The following is a description of a gene set: Human Gene Set: GSE3039_CD4_TCELL_VS_NKT_CELL_DN studied in species Homo sapiens Three innate (B1-B, NKT, CD8aaT cells) and adaptive (B2-B, CD4T, CD8abT cells) cell-types were sorted by FACS. Three biological replicates for NKT, CD4T, CD8aaT, CD8abT cells and two biological replicates for B1 and B2 cells were generated and the expression profiles were determined using Affymetrix Mu74Av2 chip. Comparisons between the sample groups allow the identification of genes differentially expressed between the innate and adaptive cell-types. Genes down-regulated in CD4 T cells versus NKT cells. from publication Yamagata T, Benoist C, Mathis D (PMID 16623764), and this is the list of marker genes: FAAP24, AIFM2, FES, ABHD10, MVB12B, MON1B, TUBGCP2, U2AF1, SLC25A29, TAOK2, PSMD3, PSTPIP1, RPRD1B, PSMC3IP, CNGA4, POLA1, WDTC1, AGPAT1, DYNC1I2, POLE, GADD45G, PGP, ID1, HELLS, GPR27, SRBD1, THOC3, TRIB1, PA2G4, KIF17, S100A6, COMMD5, PPP6R1, ZDHHC16, RPA3, RGS7, CENPT, MAGOH, GPS2, FBXL14, NCAPG2, RNPEP, GPR143, LINS1, PIMREG, METRN, CENPW, PPM1E, NUDT22, UBE2A, FAH, WRAP53, CRYM, CEP128, SLC52A2, ESYT2, HDAC6, SS18L2, SCAMP2, ACADL, PRKAR1A, RAB37, ADAMTSL3, WDR62, SLC22A4, CEP152, USP39, RBBP8, ERCC6L, MCM4, DBI, TSPAN32, PPIL1, FZR1 (NCBI Gene Id 8855), FTO, MND1 (meiotic nuclear divisions 1), DMWD, MRPL18, EZH2, ABCC4, SLC2A9, MCF2L, ALDH1A2, ATP1A3, IFT27, BICDL2, SGMS2, CEP85, PRADC1, INTS15, USP1, RP9, LOX, ELOVL3, PPP1CA, TIMELESS, POLH, MSMO1, SUV39H1, E2F4, MAN1B1, ITGAM, ACOT8, RIOK1, HSPA12A, IFRD1, SLC39A7, FAAP20, NR1H2, TMEM63A, PYGL, EXO1, C8orf58, NCAPG, ZSWIM5, HACD2, LMF2, GPR160, PDE6D, SYPL1, DSN1, TBC1D25, FLI1, KCNK12 (NCBI Gene Id 56660), TRAF7, TPI1, MAPK4 (mitogen-activated protein kinase 4), COL5A1, GMFG, SPTBN1, GOT1, MYCBP, RASSF2, MIEF2, VEGFA, TSPO, HAS2, CCDC18, BRIP1, AAAS, SCARF1, ANP32E, PEF1, RAB27A, BCAR3, SCT, TSEN34, NT5E, JADE1, FXYD1, SSNA1, NUCB2, CPTP, RFC4, RAN, TAF6, RMND5B, ALDOB, PAM, SPRING1, CENPP, PATL1, GPD2, PCLAF, TFEB, HMGB3, C5orf15, BAMBI, SPSB3, TMEM119, KLHL11, MAP2K4, CHP1, NCAPD3, MED31, LDHA, CHD7 (NCBI Gene Id 780907), SPTSSA, GPR137, SLX4, DXO, SMC4, PTCH2, LMNB2, ARHGAP1, ACBD6, FARP1, SLC41A3, PHGDH, RASGRP4, TAF11, SFXN1, DPP9, TIGAR, MAZ, ORAI1, MZT2B, PPP1R35, DGKG, DAZAP1